Given this list of marker genes TICAM2 (NCBI Gene Id 353376), TMEM248, HDAC5, CISD1, STXBP1, IAH1, DGKH, HSD17B13, FAM120C, SRRM4, IL1RAP, PRKAA1, NPHS2, RABEP1, ABCB5, ITGB1, KIF3A, ZNF503, MYO5B, CYP2R1, C4orf33, ACSL4 (acyl-CoA synthetase long chain family member 4), ST6GAL2, MPDZ (NCBI Gene Id 8777), CLPSL2, POLDIP2, SLFN5, SLC49A4, NYNRIN, SEPSECS, RUNX1T1, CACNG3, CTNNA1, ZKSCAN1, PARPBP, HSFX3 (NCBI Gene Id 101928917), REP15, OSBP, ENOSF1, ZNF879, INA, OVOL1 (ovo like transcriptional repressor 1), MTCL1, HS6ST2, C1orf116, MID1 (NCBI Gene Id 8230), ZNF268, LINC02874, PUM2, BCL9L, CPEB1, USP12, KRAS, PDE12, RBMX, DGKE, ZC3H12B, EGR3, PEX11A, SCN1A, TMED7-TICAM2, EPN3, ZNF25, ITGB8, SMIM9, MFAP3L, PARP12, SOS1 (SOS Ras/Rac guanine nucleotide exchange factor 1), INPP5A, SLC2A4, OPALIN, TMEM50B, RAB21, ANGPTL3, GRIK2, NUDT13, ATP8A1, ABTB3, MTRR, RNF103, XKR6, MARCHF1, PADI4, COL5A2, BLTP1, DST, RDH10, AGL (NCBI Gene Id 178), TESMIN, SH3TC2, SRD5A2, ASH1L, KLHL14, HNRNPLL, ZNF648, TXNDC16, CPSF6, MEIS2, MAP4K3, COX15, ATP1B1, KDM6A, ZNF559, here is a description of the gene set: Genes predicted to be targets of miRBase v22 microRNA hsa-miR-6820-3p in miRDB v6.0 with MirTarget v4 prediction scores > 80 (high confidence targets). Human Gene Set: MIR6820_3P from publication Chen Y, Wang X (PMID 31504780) species: Homo sapiens